Given this list of marker genes ADAMTS1, ESR2, ESR1, SH2B1, INHA, IMMP2L, IRS2, TNFRSF1A, SOD1, SOX3, here is a description of the gene set: Human Gene Set: MATZUK_PREOVULATORY_FOLLICLE studied in species Homo sapiens Genes important for preovulatory follicle, based on mouse models with female fertility defects. from publication Matzuk MM, Lamb DJ (PMID 18989307) Reproduction is required for the survival of all mammalian species, and thousands of essential 'sex' genes are conserved through evolution. Basic research helps to define these genes and the mechanisms responsible for the development, function and regulation of the male and female reproductive systems. However, many infertile couples continue to be labeled with the diagnosis of idiopathic infertility or given descriptive diagnoses that do not provide a cause for their defect. For other individuals with a known etiology, effective cures are lacking, although their infertility is often bypassed with assisted reproductive technologies (ART), some accompanied by safety or ethical concerns. Certainly, progress in the field of reproduction has been realized in the twenty-first century with advances in the understanding of the regulation of fertility, with the production of over 400 mutant mouse models with a reproductive phenotype and with the promise of regenerative gonadal stem cells. Indeed, the past six years have witnessed a virtual explosion in the identification of gene mutations or polymorphisms that cause or are linked to human infertility. Translation of these findings to the clinic remains slow, however, as do new methods to diagnose and treat infertile couples. Additionally, new approaches to contraception remain elusive. Nevertheless, the basic and clinical advances in the understanding of the molecular controls of reproduction are impressive and will ultimately improve patient care.